Given this list of marker genes MBTPS1, CUL1, GRPEL2, ATP13A4, PHF2, KAT2B, SCRIB, MIR155HG, ARHGEF10, here is a description of the gene set: Genes up-regulated in peripheral blood mononuclear cell responders vs nonresponders in adults (55-64) after exposure to Fluarix, time point 28D. Comment: Gene expression related to HAI response species: Homo sapiens Human Gene Set: OVSYANNIKOVA_PBMC_FLUARIX_AGE_55_64YO_RESPONDERS_VS_NONRESPONDERS_28DY_UP from publication Ovsyannikova IG, Oberg AL, Kennedy RB, Zimmermann MT, Haralambieva IH, Goergen KM, Grill DE, Poland GA (PMID 27441275) To assess gene signatures related to humoral response among healthy older subjects following seasonal influenza vaccination, we studied 94 healthy adults (50-74 years old) who received one documented dose of licensed trivalent influenza vaccine containing the A/California/7/2009 (H1N1)-like virus strain. Influenza-specific antibody (HAI) titer in serum samples and next-generation sequencing on PBMCs were performed using blood samples collected prior to (Day 0) and at two timepoints after (Days 3 and 28) vaccination. We identified a number of uncharacterized genes (ZNF300, NUP1333, KLK1 and others) and confirmed previous studies demonstrating specific genes/genesets that are important mediators of host immune responses and that displayed associations with antibody response to influenza A/H1N1 vaccine. These included interferon-regulatory transcription factors (IRF1/IRF2/IRF6/IRF7/IRF9), chemokine/chemokine receptors (CCR5/CCR9/CCL5), cytokine/cytokine receptors (IFNG/IL10RA/TNFRSF1A), protein kinases (MAP2K4/MAPK3), growth factor receptor (TGFBR1). The identification of gene signatures associated with antibody response represents an early stage in the science for which further research is needed. Such research may assist in the design of better vaccines to facilitate improved defenses against new influenza virus strains, as well as better understanding the genetic drivers of immune responses.